Given this list of marker genes SKIL, PDE9A, HECW2, FAM162A, MEGF9, BCKDHA, PRKD1, RABL3, MMP7, PRKAB1, TSPAN6, CUEDC1, STC1, ST6GALNAC4, BICD1, CD302, RNASET2, CRYM, COBLL1, MRPL19, MCL1, SBF2, STMN3, SLC30A1, WIPF2, DUSP5, DYNC2LI1, KLHL24, GOLGA8A, SINHCAF, BHLHE40, PDK1, ZBTB20, PCSK6, CPM, ARRB1, SLC22A18, TPD52, NET1, SYTL2, KLHDC10, RNU6-1016P, SH3PXD2A, MTDH, SCIN, MUC1, FAM228B, IRF2BP2, LGALS8, ASMTL, TRPC6, GRB14, EIF5, YPEL5, HGD, JUNB, UBXN4, XRN1, EEF1A1, LMAN1, RRAGD (Ras related GTP binding D), DHRS13, VMP1, PITPNC1, MEIS1, ASPH, SLC45A3, SLC27A1, SERPINA1, IL6ST, IFI16, EEF2K, RAB3IP, ATP2C1, ZNF615, SNTB1, EGR1, PNISR, DBP, FOS, GLCCI1, SNHG14, FAM3C, HK2, MMP24OS, DNAJC3, BAZ2B, CLINT1, SLC25A27, ZNF626, FRRS1, CAMK2N1, ALDOC, PGK1, SLC1A1, TTLL3, SEZ6L2, SLC3A1, NDRG1, GAL3ST1, ZBTB18, C2orf88, MMP1, H2AC18 (H2A clustered histone 18, NCBI Gene Id 8337), ATRX, TMOD1, SPP1, PIAS1, MIB1, RDH10 (NCBI Gene Id 157506), PSD3, SSBP4, GBP5, PGPEP1, HES1, HINT3, VEGFA, DMXL1, VLDLR, SPART, ETV5, PTGS1, SPRY1, ANKRD36B, CXADR, ANTXR1, KCNK3, NFKBIZ, ATM, TSPAN1, ZNF780B, ABCA5, SF3B1, BDH2, TNFRSF11A, SLC44A1 (solute carrier family 44 member 1), ENTREP2, IER5L, RSL1D1, ZNF226, CRYBG1, RUFY3, MET, SLC6A12, SLC25A3, FAM43A, MALL, WDR1, BTN3A3, ASS1, SLC25A36, NEAT1, ATP7A, CAT, MEIS2, GSTM3, RPL37, ALDH1A2, PTP4A1, TRAPPC6A, PDK3, CA12, RBMXL1, SRSF7, DPY19L4, NADSYN1, GALK2, ARSD, STOX1, TPCN1 (two pore segment channel 1), MED6, SEMA4B, PFKFB3, DMXL2, PDS5B, PDCD4, SMOC2, SLPI, CCDC50, FAM13A (family with sequence similarity 13 member A), BBX, SPATA20, MMAA, TENT4B, NCBP3, SMPDL3A, TFPI (NCBI Gene Id 7035), TSC22D3, KDM4B, CRYZL2P, LMBRD2, WSB1, TMEM37, CERS6, ZNF770, GDPD1, KCTD6, ZNF350, TM4SF4, KANSL1L, FAM83A, H6PD, CTBS, PIK3R1, H19, MRAP2, SLC7A11 (NCBI Gene Id 23657), AMY1A, PKD2, SMIM6, RICTOR, TMEM47, TM7SF2, IFI27, TARS3, ANKRD50, CD55, DUSP6, RAP1GAP, IFITM1, RALGPS2, BRWD1, HLA-DMA, HDAC4, HTRA1, PABPC1, N4BP2L2, GRB7, PNP, ARHGAP18, ZNF253, CNIH1, TP53INP1, PAXBP1, TMEM106B, MKLN1 (NCBI Gene Id 55782), SORBS2, CHD2, SLC40A1, GLRX, LSM8, TRIM13, ADM, KCNK5, FSBP, SELENOP, ANKRD29, NREP, NAV1, PROS1 (NCBI Gene Id 5627), GALNT3, FAM107B, SULT1C2, RXFP1, DHRS3 (dehydrogenase/reductase 3), HELZ (helicase with zinc finger), H3-3B, NT5E, GOLGA2P5, HEY1, DPP4, MINDY2, SCAMP1, TTC3, VAV3, YIPF6, GALNT14, C8orf44, TCIRG1, MAST4, MSI2, CYS1, RESF1, LAMB1, GDF15, FUT11, SECISBP2L, MRNIP-DT, SALL1, P4HA1, MALAT1, SEPTIN6, MGAT4A, DCAF16, MYEF2, GABARAPL1, TM2D3, FLRT3, LCN2, MAFF, BST2, PLEKHA1, GPD1L, SCD, MARCKSL1, JAK3, VPS13A, APOOL, MXI1, ARL17B, AK4, ZC3H11A, NEBL, NAP1L1 (NCBI Gene Id 64165), XIST, UGT1A10, CDK19, PIGP, TM9SF3, MPZL2, C11orf58, SGK2, PLOD2, TMC5, ZNF320, SPRY2, SLC2A10, ABRAXAS1, AMN1, ARL14, DYNC2H1, SAT1, SLC9A7, ZNF207, IDO1, HLA-E, IER2, FAM110C, BTN3A2, PPP1R9A, BPTF, TFDP2, DNAH12 (NCBI Gene Id 8679), PARP8, CHGA, UCP2, GPN2, NKTR, GBE1, VAC14-AS1, THBD, PTER, SEC62, ACSM3, PAPSS2, MZF1, MIGA1, ISG20, RPL31, P4HTM, RBM39, TNFSF10, GAS2L3, PRUNE2, ZNF397, NCALD, CARD8, ST3GAL6, ZMYM2, DEPTOR, ACER3, CNTNAP3, BNC2, DDIT4, ATOSA, C5orf24, PTEN, CUL4B, FRG1HP, CASZ1, NBN, ESR1, RSF1, CDK12, RBM47, CKB, NDUFS1, C14orf28, SLC9A1, SERPINB1, SF1, BTG1, MRFAP1L2, CDH1, RFX3, ZNF614 (NCBI Gene Id 90346), MBOAT2, KRCC1, NT5DC1, TMED4, CGNL1, CRIPT, LAMP2, LINC02683, VPS13B, SLC20A1, SMCHD1, PLCG2, ALG13, here is a description of the gene set: species: Homo sapiens Genes down-regulated in SKOC-3 cells (ovarian cancer) after YB-1 (YBX1) knockdown by RNAi. Y-box-binding protein 1 (YB-1), which is a member of the DNA-binding protein family containing a cold-shock domain, has pleiotropic functions in response to various environmental stimuli. As we previously showed that YB-1 is a global marker of multidrug resistance in ovarian cancer and other tumor types. To identify YB-1-regulated genes in ovarian cancers, we investigated the expression profile of YB-1 small-interfering RNA (siRNA)-transfected ovarian cancer cells using a high-density oligonucleotide array. YB-1 knockdown by siRNA upregulated genes, including MDR1, thymidylate synthetase, S100 calcium binding protein and cyclin B, and downregulated genes, including CXCR4, N-myc downstream regulated gene 1, E-cadherin and phospholipase C. Exogenous serum addition stimulated YB-1 translocation from the cytoplasm to the nucleus, and treatment with Akt inhibitors as well as Akt siRNA and integrin-linked kinase (ILK) siRNA specifically blocked YB-1 nuclear localization. Inhibition of Akt activation downregulated CXCR4 and upregulated MDR1 (ABCB1) gene expression. Administration of Akt inhibitor resulted in decrease in nuclear YB-1-positive cancer cells in a xenograft animal model. Akt activation thus regulates the nuclear translocation of YB-1, affecting the expression of drug-resistance genes and other genes associated with the malignant characteristics in ovarian cancer cells. Therefore, the Akt pathway could be a novel target of disrupting the nuclear translocation of YB-1 that has important implications for further development of therapeutic strategy against ovarian cancers. Human Gene Set: BASAKI_YBX1_TARGETS_DN from publication Basaki Y, Hosoi F, Oda Y, Fotovati A, Maruyama Y, Oie S, Ono M, Izumi H, Kohno K, Sakai K, Shimoyama T, Nishio K, Kuwano M (PMID 17072343)